Given this list of marker genes MAP3K20, STAT5A, SLC25A39, GK, DND1, CD209, SLC6A20, CGAS, NSUN5, EPHX2, CNMD, MCM2, MGAT2, HAUS2, MGAT4A, OVCA2, ZDHHC5, TMED7 (transmembrane p24 trafficking protein 7), CYSTM1, XPO4, LRPPRC, NPHP1, RERG, RAB25, RNASE6, SPATS2L, UFSP1, FCMR, NOLC1, ZNF706, B3GNT8, SPMIP6, EFHB, CCDC73, POM121, AKAP1, SKP2, HSPBP1, DOCK5, LEAP2, LAD1, UBXN2A, DDX39B, LYNX1, PHF20 (PHD finger protein 20), CUL5, SFRP2, DNAL4 (dynein axonemal light chain 4), TCEAL8, SNN, TBC1D16, HELLS, SLC46A1, VDAC3, PRICKLE1, CCNE1, HSPA9, STAT5B, NOA1, MAPDA, PHLPP1, KYNU, IRF8, H2AZ1, SLC39A2, PBRM1, FCRL1, SEPTIN2, DIXDC1 (DIX domain containing 1), IL21R, ATRNL1, NID1, HSPB9, AGAP2, WIPF3, IRF9, KNOP1, SWAP70, LIPT2, HP, GRM1, BRD10, PHKA1, LIPA, RBM27, LARS2, ARMC9, EXOSC3 (exosome component 3), LY6D, CCDC172, POU3F3, QPCT, CLUH, PSMA5, GINS2, TNFRSF13B, IL17RD, SAA1, MBLAC1, IGF2-AS, TNFRSF13C, CDH3, PTRH1, SLC25A6 (solute carrier family 25 member 6), PLAUR, CYB561A3, FKBP6, ABI3, SIL1, AADAC, RCOR1, MAGOH, TCF4, RCN2, SYNCRIP, ECT2, SUPV3L1, NFKBIE, LARP1, PAM (NCBI Gene Id 5066), THG1L, ATP8B1, PPP1R36, EHD4, CD180, DBP, MED1, CCNK, LAMTOR5, RUNDC3B, AP2A2, KLHL32, TESMIN, NDRG3, UBA6, GOLM2, FGF6, TCERG1, PIGR, GPX6, GPR34, SHBG, AHCYL1, ING5, LYZL4, SNX30, SPCS2, TMEM186, FOXC2, NUDCD2, ACSL1, ASF1B, TCEAL7, RRM2, ACKR3, PDE11A, ZNF428, KMO, TMEM231, ABCE1, SLC15A5, INTS2, RASGRP3, IL12B, TSPAN33, HOXA13, IL17B, CCT2, MRPL44, ALG10, MORC3, PRDM8, SLC6A9, PHLDA3, ATAD5, FAM167A, SELENBP1, PLAC1, JCHAIN, PDIK1L, SOX18, SPMIP3, GPR3, FPR1, FUT10, SLC25A20, STMN3, PRR16, KCTD16, DPAGT1, RAC3, DOK3, ADAM9, FDPS, REEP3, FAM83G, CHAC1, EFHD1, ATP6V1C2, DCUN1D4, here is a description of the gene set: To obtain insight into the genetic basis of the increase of functional activity of memory B cells over time, we compared the gene expression profiles of day 7 and day 40 NP-specific/IgG1 memory B cells, GC B cells and plasma cells in immunized WT mice and naïve B cells, before and after activation in vitro. Genes up-regulated in day 7 plasma cells versus day 40 germinal center B cells. from publication Kaji T, Ishige A, Hikida M, Taka J, Hijikata A, Kubo M, Nagashima T, Takahashi Y, Kurosaki T, Okada M, Ohara O, Rajewsky K, Takemori T (PMID 23027924) species: Homo sapiens Human Gene Set: GSE11961_PLASMA_CELL_DAY7_VS_GERMINAL_CENTER_BCELL_DAY40_UP